The following is a description of a gene set: Human Gene Set: GOBP_RESPONSE_TO_KETONE A response that results in a state of tolerance to ketone. species: Homo sapiens, and this is the list of marker genes: CSN1S1, NCOA4, RELA, YAP1, AKAP8, DSG1, SCNN1G (NCBI Gene Id 6340), TGFBR3, ADCY5, AKT1, FOXP3, TXNIP, EDN1, TFAP4, FOXP1, PTGDR, CD38, STK39, CBL, ADCY6, CARD9, KLF2, EPO, ADCY3, F7, HOXD13, SOX10, ACOD1, NR3C1, FOXO3, GHSR, HOXA11, GNAI1, SPP1, NKX2-2, PTGER1, DDIT4, HPCA, ELK1, PSPH, NCOA2, TGFB3, KLF4, TGFB1, SLC12A3, CEBPA, COMT, AQP1, PLN, USP8, ABHD2, ACACA, LARP1, SGK1, GNB1, SCNN1A, TRERF1, FECH, PARP1, SLIT2, METTL21C, GNG2, TACR1, NR1H3, GBA1, CYP1A1 (NCBI Gene Id 1543), HNRNPD, CYBA, CDA, P2RY6, IFITM5, SLIT3, GNAS, ROCK2, HOXB13, CCND1, PCK2, MTAP (methylthioadenosine phosphorylase), AKR1C2, RPS6KB1, HDAC6, PRKN, PRKCA (protein kinase C alpha), GOLPH3, FGF2 (NCBI Gene Id 2247), FOSB, TAT, VPS54, SFRP1, IGFBP7, SREBF1, PRKAA1, ABCB4, SRD5A1 (steroid 5 alpha-reductase 1), DSG2, PIM3, PARK7, BTG2, SLC5A5, DEFB104A, ASS1, SCNN1D, HOXA13, HOXA9, CFTR, GLB1, PPP1R9B, MIR342, ADCY8, UCP3, AARD, TNFSF4, NCF1, SIRT1, NCOA1, AIFM1, KLF9, HMGCS2, UBE3A, TSPO, CCR7, CASP9, SLC39A9, ADCY1, PCK1, BGLAP, UGT3A2, PRKCE, DUSP1, CYBB, CCL21, GAS6, SH3RF1, SMYD3, MSN, UCP1, INHBA, ERRFI1, SRC, FBP1, CLDN4, SCNN1B, GNAQ, CAD, CLDN1, CDK4, EFNA5, AXIN2, NEFL, CBX3, CPS1, EIF4E, ATP5F1A, AVPR1A, BORCS7, NKX3-1, XRN1, PTGDR2 (prostaglandin D2 receptor 2), POR, PIK3CA, AVP, OXT, PTGER4, PRKD1, AHR, GHR, CALM3, PRKAA2, AR, SCN11A, CALR, FBXO32, TBXA2R, PTPRC, GPI, CCL19, AKR1C3, MAP4K1, SPHK2, GNRH1, BMI1, HCN2, CRH, F5, PCNA, AANAT, CREB1, ITGAM, P2RY4, TGFB2, POSTN, RWDD1, TBX2, NPAS4, SIN3A, SRD5A2, JAK2, PTGFR, ANKRD13C, BCL2L1, THBS1, NTRK3, MSTN, ADAM15, GABRB1, ABCB1, TNC (NCBI Gene Id 3371), SERPINF1, GKN2, WBP2, FOS, ADCY2, PTGER2, CAV1, HDAC3 (NCBI Gene Id 8841), HSF1, LIPA, SP1, FDX1, UCN3, UCP2, NASP, CFLAR, CA9, HOXA10, DEFB104B